The following is a description of a gene set: The progression of the artery over time, from its initial formation to the mature structure. An artery is a blood vessel that carries blood away from the heart to a capillary bed. studied in species Homo sapiens Human Gene Set: GOBP_ARTERY_DEVELOPMENT, and this is the list of marker genes: HOXA13, ADGRF5, NOG, CHD7, EDN1, MIR29B1, MYLK, NPRL3, MIR494, MIR153-1, HES1, SEC24B, SIX1, BMP4, HEY1, TBX2, LRP1, RTN4, APOB (NCBI Gene Id 338), CITED2, NKX3-1, MIR487B, FAM3D, ENG, WNT11, TBX1, SUFU, MIR205, TFAP2B, GAA, NDST1 (NCBI Gene Id 3340), TGFBR1, LUZP1, COMP, LDLR, FOLR1, TGFB2, MIR145, PRICKLE1, MYOCD, PDGFRB, SRF, ADAMTS6, NF1, FOXF1, FOXC2, PDE2A, PRDM1, PRRX1, MEGF8, EYA1, PCDHA10, ACVR2B, CNTRL, SNX17, NOTCH1, HOXA1, GJA5, NFATC3, EGR2, SHH, ROBO1, ZMIZ1, LEP, MIR495, JAG1, SCN11A, BMPR1A, PKD2, NAGLU, SMAD6, FOXC1, LOXL1, MIR329-1, RBPJ, ACVRL1, PLXND1, TAB1, MDK, HHIPL1, DLL4, ADAMTS9, PROX1, APOE, BMPR2, ARID2, HAND2 (NCBI Gene Id 9464), APLNR, TGFBR2, NRP1, NOTCH3, FKBP10, EDNRA, MIR143, EFEMP2, GLI3, COMT (NCBI Gene Id 1312), DCTN5, HECTD1, FGF8, LRP2, ANGPTL3, ROBO2, MYH10, HPGD, AKT3, STRA6 (signaling receptor and transporter of retinol STRA6), SOX4, LOX, SMAD7, SLC2A10, COL3A1 (collagen type III alpha 1 chain), VEGFA, EFNB2, AP2B1, DDIT3, NGFR, HEY2, FOXH1